The following is a description of a gene set: species: Homo sapiens Human Gene Set: MIR6790_3P from publication Chen Y, Wang X (PMID 31504780) Genes predicted to be targets of miRBase v22 microRNA hsa-miR-6790-3p in miRDB v6.0 with MirTarget v4 prediction scores > 80 (high confidence targets)., and this is the list of marker genes: SMG1, ATP8A2, MRFAP1, APLN, ATP6V0E1